Given this list of marker genes LAMA2 (NCBI Gene Id 3908), FKRP, TTN, SELENON, MYH7, here is a description of the gene set: Human Gene Set: HP_ABNORMAL_MUSCLE_FIBER_MEROSIN_EXPRESSION studied in species Homo sapiens An anomalous amount of merosin in muscle fibers. Merosin is a basement membrane-associated protein found in placenta, striated muscle, and peripheral nerve. Abnormal muscle fiber merosin expression